Given this list of marker genes FTH1, HPX, TF, SRI, MT2A, MYC (MYC proto-oncogene, bHLH transcription factor), HFE, TFRC, LTF, CP, here is a description of the gene set: studied in species Homo sapiens Iron ion homeostasis. Human Gene Set: MODULE_540